The following is a description of a gene set: Human Gene Set: GOBP_NATURAL_KILLER_CELL_CYTOKINE_PRODUCTION species: Homo sapiens Any process that contributes to cytokine production by a natural killer cell., and this is the list of marker genes: HLA-G, CD96, CALHM6, CLNK, CD160, IL21, RAET1G, CD226, KIR2DL4 (killer cell immunoglobulin like receptor, two Ig domains and long cytoplasmic tail 4), HLA-F, HLA-E